Given this list of marker genes Cs, Csnk1a1, Atp6ap1 (NCBI Gene Id 54411), Atp1a1, Nsf, Oaz2, Calm2, Actr3, Skp1, Tubb4b, Srsf5, Cck, Tubb3, Eef1g, Nptx1, Ddx3x, Pld3, Ncl, Gabra1, Septin7, Dctn1, Ppp2ca, Cdk16, Rab2a, Mgll, Dync1h1, Ap2m1, Eif4g3, Mag, Aco2, Ppm1a, Ptgds, Hsp90ab1, Kcnma1, Rab14, Csde1, Arpp19, Dad1, Syt1, Dnm1, Cplx1, Ppp1cb, Nme1, Tia1, Pfn1, Atp1b2, Apoe (NCBI Gene Id 11816), Atp6v1e1 (ATPase, H+ transporting, lysosomal V1 subunit E1), Dnajb11, here is a description of the gene set: Mouse Gene Set: JIANG_AGING_CEREBRAL_CORTEX_DN Down-regulated in the cerebral cortex of aged (22 months) BALB/c mice, compared to young (2 months) controls studied in species Mus musculus A better understanding of the molecular effects of aging in the brain may help to reveal important aspects of organismal aging, as well as processes that lead to age-related brain dysfunction. In this study, we have examined differences in gene expression in the hypothalamus and cortex of young and aged mice by using high-density oligonucleotide arrays. A number of key genes involved in neuronal structure and signaling are differentially expressed in both the aged hypothalamus and cortex, including synaptotagmin I, cAMP-dependent protein kinase C beta, apolipoprotein E, protein phosphatase 2A, and prostaglandin D. Misregulation of these proteins may contribute to age-related memory deficits and neurodegenerative diseases. In addition, many proteases that play essential roles in regulating neuropeptide metabolism, amyloid precursor protein processing, and neuronal apoptosis are up-regulated in the aged brain and likely contribute significantly to brain aging. Finally, a subset of these genes whose expression is affected by aging are oppositely affected by exposure of mice to an enriched environment, suggesting that these genes may play important roles in learning and memory. from publication Jiang CH, Tsien JZ, Schultz PG, Hu Y (PMID 11172053)